Given this list of marker genes Dsp, Plekhg5, Nisch, Flot2, Ubxn11, Arhgap21, Wdr6, Ptpn13, Ktn1, Rbm39, Txnl1, Sema4f, Pik3r2, Rnd3, Vangl2, Dst, Pik3r1, Tnfaip1, Ankrd26, Depdc1b, Vangl1, Kctd13, Scrib, Arhgap5, Fam83b (NCBI Gene Id 208994), Cav1, Ccdc88a, Tmod3, Muc13, Epha2, Rasal2 (RAS protein activator like 2), Dlg5, Picalm, Rbmx, Rock1, Ckap4, Dsg1a, Arhgap35, Pkp4, Cpd, Ckb, here is a description of the gene set: RND3 GTPase cycle Mouse Gene Set: REACTOME_RND3_GTPASE_CYCLE species: Mus musculus